The following is a description of a gene set: Human Gene Set: HP_HYPOGLYCORRHACHIA Abnormally low glucose concentration in the cerebrospinal fluid. Hypoglycorrhachia species: Homo sapiens, and this is the list of marker genes: TICAM1, TBK1, TLR3, UNC93B1, TRAF3, SLC2A1